Given this list of marker genes CD1B, HPRT1 (hypoxanthine phosphoribosyltransferase 1), CD1D, CD1C, TYMS, STMN1, CD1E, ERCC1, ADA, TOP2A, MCM4, DNTT, UNG, TK1, MCM5, MAD1L1, CCNA2, RPA1, CD1A, PTPRF, TLX1, MTHFD1, MME (membrane metalloendopeptidase), here is a description of the gene set: Human Gene Set: FERRANDO_HOX11_NEIGHBORS studied in species Homo sapiens Human T cell leukemias can arise from oncogenes activated by specific chromosomal translocations involving the T cell receptor genes. Here we show that five different T cell oncogenes (HOX11, TAL1, LYL1, LMO1, and LMO2) are often aberrantly expressed in the absence of chromosomal abnormalities. Using oligonucleotide microarrays, we identified several gene expression signatures that were indicative of leukemic arrest at specific stages of normal thymocyte development: LYL1+ signature (pro-T), HOX11+ (early cortical thymocyte), and TAL1+ (late cortical thymocyte). Hierarchical clustering analysis of gene expression signatures grouped samples according to their shared oncogenic pathways and identified HOX11L2 activation as a novel event in T cell leukemogenesis. These findings have clinical importance, since HOX11 activation is significantly associated with a favorable prognosis, while expression of TAL1, LYL1, or, surprisingly, HOX11L2 confers a much worse response to treatment. Our results illustrate the power of gene expression profiles to elucidate transformation pathways relevant to human leukemia. from publication Ferrando AA, Neuberg DS, Staunton J, Loh ML, Huard C, Raimondi SC, Behm FG, Pui CH, Downing JR, Gilliland DG, Lander ES, Golub TR, Look AT (PMID 12086890) Nearest neighbors of HOX11, based on the close agreement of their expression profiles with that of HOX11 in pediatric T cell acute lymphoblastic leukemia (T-ALL).